The following is a description of a gene set: part of: Muscle contraction Layers of smooth muscle cells can be found in the walls of numerous organs and tissues within the body. Smooth muscle tissue lacks the striated banding pattern characteristic of skeletal and cardiac muscle. Smooth muscle is triggered to contract by the autonomic nervous system, hormones, autocrine/paracrine agents, local chemical signals, and changes in load or length.<br> Actin:myosin cross bridging is used to develop force with the influx of calcium ions (Ca2+) initiating contraction. Two separate protein pathways, both triggered by calcium influx contribute to contraction, a calmodulin driven kinase pathway, and a caldesmon driven pathway.<br> Recent evidence suggests that actin, myosin, and intermediate filaments may be far more volatile then previously suspected, and that changes in these cytoskeletal elements along with alterations of the focal adhesions that anchor these proteins may contribute to the contractile cycle.<br> Contraction in smooth muscle generally uses a variant of the same sliding filament model found in striated muscle, except in smooth muscle the actin and myosin filaments are anchored to focal adhesions, and dense bodies, spread over the surface of the smooth muscle cell. When actin and myosin move across one another focal adhesions are drawn towards dense bodies, effectively squeezing the cell into a smaller conformation. The sliding is triggered by calcium:caldesmon binding, caldesmon acting in an analogous fashion to troponin in striated muscle. Phosphorylation of myosin light chains also is involved in the initiation of an effective contraction.<br> studied in species Homo sapiens Reactome Pathway: Smooth Muscle Contraction, and this is the list of marker genes: LMOD1, SORBS3, TPM3, CAV3, MYL9, MYL12A, PDE5A, TLN1, PXN, ALDH2, ANXA2, CACNA1H, MYL12B, MYL10, MYL11, ACTA2, DYSF, CALD1, TRIM72, ACTG2, CACNA1I, GUCY1A1, MYLK, VCL, GUCY1B1, PAK1, MYL7, SORBS1, MYL5, TPM2, ITGB5, ANXA6, PAK2, CALM1, MYL6B, ANXA1, TPM1, TPM4, GUCY1A2, ITGA1 (integrin subunit alpha 1), MYL6, GUCY1B2, MYH11, CACNA1G